The following is a description of a gene set: The series of molecular signals in which an intracellular signal is conveyed to trigger the apoptotic death of a cell. The pathway is induced in response to oxidative stress, a state often resulting from exposure to high levels of reactive oxygen species, and ends when the execution phase of apoptosis is triggered. Mouse Gene Set: GOBP_INTRINSIC_APOPTOTIC_SIGNALING_PATHWAY_IN_RESPONSE_TO_OXIDATIVE_STRESS studied in species Mus musculus, and this is the list of marker genes: Stk25, Nox1, Prodh, P4hb, Bcl2, Hif1a, Zfp622, Pink1 (NCBI Gene Id 68943), Ctnnb1, Fbxo7, Ubqln1, Sfpq, Trem2, Atf4, Arl6ip5, Nfe2l2, Sod2, Mapk7, Gskip, Sod1, Jak2 (NCBI Gene Id 98155), Trap1, Melk, Map3k5, Uaca, Diablo, Fgf2, Rnf7, Gpx1, Sirt1, Pdk1, Mcl1, Mmp2, Fzd1, Gata4, Pdcd10, Aldh2, Rack1, Vnn1, Cyp1b1, Prkn, Fyn, Map2k4, Hspb1, Adcy10, Pycr1, Nme5, Il10, Nol3, Mapt, Nono, Bag5, Ppia, Fbxw7, Pml, Stk24, Wnt1, Park7, Daxx, Parp1